Given this list of marker genes THRA, ADRA2A, AKR1D1, CYP4F12 (cytochrome P450 family 4 subfamily F member 12), ALDH3B1, APOC1, PNPLA6, SMPDL3A, AKR1B10, PLA2G4C, ECHS1, LDAH, SGPP2, CYP27B1, GLYATL2, AUH, PLA2G12B, HINT2, MTLN, PLBD2, SULT1E1, PNPLA3, MCAT, SLC27A4, CROT, HSD17B11, LIPJ, PEX5, APOA2, PLA2G2A, PLBD1, APOC2, VPS54 (NCBI Gene Id 51542), PCK2, MIR16-1, ASAH2, LPIN1, ADORA1, PLA2G5, ETFA, PLIN5, SRD5A3, PHYH, HADH, PRKCD, SCT, IL1B, PLA2G2E (NCBI Gene Id 30814), NCEH1, OC90, NEU4, ACACB, CPT2, ACER3, ECI2 (enoyl-CoA delta isomerase 2), PLCD3, PAFAH1B2, CPT1B, PLA2G4F, PEX13, ABHD12B, RAB7A, DPEP1, PNLIPRP3, LIPE, PLPP2, HCAR1, NAGA, PNPLA4, SPP1, NEU3, IVD, ABCB11, SIRT2, PNPLA8, LIPF, NUDT7, PLA2G10, SCARF1, ACADM, ACAD10, CYP24A1, HEXB, SIRT6, SMPD2, PLA2G7, GALC, ECHDC2, SPHK1, ALDH3B2, TWIST1 (NCBI Gene Id 7967), SORL1, DECR1, ETFB, PLCH1, FUT1, APOE, ENPP2, CLPS, ABCD2, CYP39A1, ASAH2B (NCBI Gene Id 653308), APOA5, APOA4, GBA3, NAPEPLD, GLB1, ABHD4, PAFAH1B3, LDLR, GBA2, ACER2, PLCD1, CYP19A1 (cytochrome P450 family 19 subfamily A member 1), PDE3B, LYPLA2, DGKD, PLA2G2C, ACOXL, PLCXD2 (NCBI Gene Id 257068), CIDEC, CYP2W1, LPL, DAGLA, ACAA1, LIPC, PLCG2, PLIN1, PEX2, CYP1A2, PPARA, AKR1C3, ALK, SRD5A1, ABHD2, M6PR, ABHD1, ILVBL, OXCT2, GM2A (ganglioside GM2 activator), HADHB, ACOX2, BCO2, OXCT1, FAAH, PEX7, ACADVL, NUDT8, PLCE1, TYSND1, ETFDH, INS, CLPSL1, LCT, ECH1, BDH2, ZPBP2, PLA2G6, HPGD, NEU2, ACAD11, CYP27A1, ACADL, HSD17B10, LIPM, ENPP6, LEP, SLC27A2, SESN2, CLPSL2, MGLL, CYP4A11, PLA2G4E, CEL, DAGLB, SCARB1, CES1, CRTC3, AMACR, PLAAT3, PLA2G4A (NCBI Gene Id 5321), SGPL1, PLA2G2F, SPART, SMPD3, CYP1B1, APOC3, ECHDC1, PLB1, SMPD4, PLAAT2, GBA1, INPP5F, LRCOL1, ABHD6, BSCL2, ABHD12, LIPG, PLA2G2D, PPARD, PRKAA1, CYP26A1, AKT2, FAAH2, ALDH1L2, TNF, FMC1, IRS1, ACOT7, PLCB3, GDPD3, ECI1, DECR2, HADHA, CYP4F3, MIR127, ABHD16A, ACAT1, ETNPPL, PLAAT1, ABHD16B, HAO1, CPS1, ABCD3, PNPLA1, NEU1, PNLIP, PNLIPRP1, GCDH, PLA2G4B, PCCB, ACER1, AOAH, CYP7A1, GPCPD1, MLYCD, PLPP1, CYP26B1, BCO1, PCCA, AIG1, EHHADH, MFSD2A, HACL1, SUMF1, CLSTN3, SMPD1, PLCG1, NAGLU, ADIPOQ, PNPLA2, PLD6, ABHD3 (NCBI Gene Id 90492), FGF23 (NCBI Gene Id 8074), CYP26C1, PLA2G15, LIPI, ACBD5, HSD17B4, SCARB2, APOB, PNLIPRP2, STS, CYP3A4, ACOX3, FUCA1, PRDX6, PLA1A, HSD17B14 (NCBI Gene Id 51171), YWHAH, PPT1, NAAA, CIDEA, SNX17, DPEP2, PLPP6, RARRES2, SMPDL3B, PIK3CG, PLCB4, ABCD4, CYP46A1, ACOX1, HSD11B1, PLCH2, ABCD1, DDHD2, CPT1A, ACAA2, SRD5A2, LIPN, PNPLA5, ABHD15, HSD17B6, ASAH1, GPLD1, CYP4F2, PLA2G12A, HCAR2, HEXA, PLCZ1, IDH1 (NCBI Gene Id 3417), ABHD5, PLCB1, LIPK, IAH1, ENDOU, TBL1XR1, MCEE, SGPP1, PAFAH1B1, PLAAT4, LIPA, PLCB2, ASPG, FITM2, LPIN2, PRKCE, LONP2, PLPP3, SCP2, PLA2G4D, ANGPTL3, GDE1, ADTRP, MGST2, PNPLA7 (NCBI Gene Id 92716), LPIN3, NUDT19, ACOT8, PLD2, GLA, AADAC, IRS2, PAFAH2, PLA2G1B, SULT2A1, MIR195, ACADS, LIPH, SLC25A17, ENPP7, CRAT, ENSG00000293349, GDPD1, PLD1, PLCXD3, PLCD4, PCK1, AKT1, ETFBKMT, GPIHBP1, here is a description of the gene set: The chemical reactions and pathways resulting in the breakdown of lipids, compounds soluble in an organic solvent but not, or sparingly, in an aqueous solvent. Human Gene Set: GOBP_LIPID_CATABOLIC_PROCESS studied in species Homo sapiens